The following is a description of a gene set: Pathway Definition from KEGG: FN1 -> (ITGA+ITGB) -> (SRC,PTK2) -> (PXN,CRK+BCAR1) -> (DOCK1+ELMO1) -> RAC ITGA/B-FAK-RAC signaling pathway. Pathway ID: N01068. Pathway type: Reference. Pathway class: nt06135 Cytoskeletal regulation (viruses and bacteria). Human Gene Set: KEGG_MEDICUS_REFERENCE_ITGA_B_FAK_RAC_SIGNALING_PATHWAY studied in species Homo sapiens, and this is the list of marker genes: BCAR1, SRC (NCBI Gene Id 6714), ITGB1, CRK, PXN, FN1, PTK2, ITGAV, RAC3, RAC1, ELMO1, ITGA10, ITGA7, ITGB5, DOCK1, ITGA3, ITGB3, ITGA2B, ITGB6, ITGA9, ITGA1, ITGA5, ITGA4, RAC2, ITGB8, ITGB7, ITGA11 (NCBI Gene Id 22801), ITGA2, ITGB4, ITGA8 (NCBI Gene Id 8516)